The following is a description of a gene set: from publication Chen Y, Wang X (PMID 31504780) Genes predicted to be targets of miRBase v22 microRNA mmu_miR_6943_3p in miRDB v6.0 with MirTarget v4 prediction scores > 80 (high confidence targets). studied in species Mus musculus Mouse Gene Set: MIR_6943_3P, and this is the list of marker genes: Tfap2c, Scamp2, Kif3b, Slc43a2, Prpf4b, Lamp2, Ccn4, Xlr5b, Bmpr1b, Erbb4, Mab21l2, Cyld, Zfp426, Zfp367, Ago1, Zmat3, Hpgds, Syt1, Cdkn1b, Srsf2, Tgfbr1, Agap1, Pramel42, Jmy, Fam3d, Tex2, Wee2, Tle4, Nfatc3, Abcc1, Iqsec2, Cyp2c50, Fam3c, Gxylt1, Crebrf, Aadacl2fm1, Stat4, Pappa, Arid4a, Npnt, Ces2a, Atrn, Negr1 (neuronal growth regulator 1), Tnr, Zmynd8, Entrep2, Slc8a1, Rnf122, Pramel57, Sh3bp5, Zfp811, Lrrc7, Bbx (bobby sox HMG box containing), Pank3, Kcnip1, Pbrm1, Txndc12, Ell2, Etnk1, Lrrc8a, Bmi1, Cdo1, Gmfb, Iqcb1, Cdin1, Numb, Wsb1, Lratd2, Arhgef3, Orc5, Pfkp, Otub2, Gpcpd1, Trpm1, Slc4a8, Timp4, Fkbp5, Xlr5a (X-linked lymphocyte-regulated 5A), Smim19, Zfp316, Wdfy1 (WD repeat and FYVE domain containing 1), Hpcal4, Abhd17a, Adcy9, Pcsk2, A830018L16Rik, Rerg, Zfc3h1, Ep300, Atf7ip, Elovl1, Tub, Rc3h2, Naa40, St3gal3, Pramel55, Tbc1d30, Mtx3, D630023F18Rik, Tspan2, Nfia (NCBI Gene Id 68838), Fhod3, Casc3, D630045J12Rik, Tmem164, Nckap1l, Dzip1, Sh3rf3